The following is a description of a gene set: Any process that modulates the frequency, rate or extent of oxidoreductase activity, the catalysis of an oxidation-reduction (redox) reaction, a reversible chemical reaction in which the oxidation state of an atom or atoms within a molecule is altered. One substrate acts as a hydrogen or electron donor and becomes oxidized, while the other acts as hydrogen or electron acceptor and becomes reduced. species: Mus musculus Mouse Gene Set: GOBP_REGULATION_OF_OXIDOREDUCTASE_ACTIVITY, and this is the list of marker genes: Fxn, Cdh3, Gch1, S100a1, Esr1, Nus1, Fcer2a, Edn1, Edn2, Slamf8, Cav3, Terf2, Lep, Phb2, Oxa1l, Sirt4, Cox17, Eng, Park7, Dhfr, Gfi1, Slc4a1, Fgf23, Il1b, Prkn, Atp7a, Mt3, Sphk2, Sdhaf4, Akt1, Htr2b, Ecsit, Ifng, Abl2, Scarb1, Nosip, Abl1, Cyp27b1, Gla, Ins1, Prdx5, Rfk, Tert, Ins2 (NCBI Gene Id 16334), Por, Drd5, Ftmt, Nfkb1, Tnf, Atp2b4, Gzma, Cav1, Sirt3, Lgals9, Sirt5, Snca, Gdnf, Sco1, Coa8, Ccs, Vdr, Taco1, Ndufa4 (Ndufa4, mitochondrial complex associated), Ripk3, Szt2